Given this list of marker genes Pdha2, Kat2a, Dlst, Pdk2, Dbt, Pdha1, Mrps36, Pdhx, Abhd11, Dhtkd1, Bckdhb, Dld, Pdhb, Bckdha, Ogdh, Ogdhl, Bckdk, Pdk1, Dlat, here is a description of the gene set: A multi-enzyme complex that catalyzes the oxidative decarboxylation of an alpha-ketoacid - pyruvate, a branched-chain alpha-ketoacid or alpha-ketoglutarate (also known as 2-oxoglutarate). The complex comprises multiple copies of three enzymes referred to as E1, E2 and E3: a dihydrolipoyl transacylase (E2) forms the core of the complex, with an alpha-ketoacid dehydrogenase (E1) and a dihydrolipoamide dehydrogenase (E3) attached through non-covalent bonds. The E1 and E2 components are specific to different alpha-ketoacid dehydrogenase complexes, whereas the E3 component is the same. Additional proteins may also be present. studied in species Mus musculus Mouse Gene Set: GOCC_ALPHA_KETOACID_DEHYDROGENASE_COMPLEX